Given this list of marker genes Shh, Ctnnb1, Nfib, Fgfr2, Tbx2, Phf14, here is a description of the gene set: studied in species Mus musculus Mouse Gene Set: GOBP_MESENCHYMAL_CELL_PROLIFERATION_INVOLVED_IN_LUNG_DEVELOPMENT The multiplication or reproduction of cells, resulting in the expansion of a mesenchymal cell population that contributes to the progression of the lung over time. A mesenchymal cell is a cell that normally gives rise to other cells that are organized as three-dimensional masses, rather than sheets.